Given this list of marker genes F3 (NCBI Gene Id 99486), Dusp1, Pkp1, Inmt, Car2, Fos, Myh9, Kitl, Epcam, Ccn2 (cellular communication network factor 2), Nrp1, Klf2, Klf10, Zfp36, Prkcz, Krt14, Cyp2f2, Jup, Egr1, Fzd8, Flna, Ctnnd1, Actn4, Plk2, Arhgef1, Sgk1, Id4, Sat1, Tsc22d1, Serpinb5, Itpr1, Id1, Tiam1, Chka, Id2, Stat5a, Atp1a1, Btg2, Pcx, Hmmr, Grb7, Fbp2, Numb (NUMB endocytic adaptor protein), Itgb5, Vamp8, Thbs1, Hmga2, Zfp239, Irf6, Amd1, Cdh1, Atf3, Bmp4, Padi2, Egr2, Ctsh, Nr4a1, Tgfb3, Timp3, Nnt, Tgm2, Bcl6, here is a description of the gene set: Epithelial-to-mesenchymal transition (EMT), a switch of polarized epithelial cells to a migratory, fibroblastoid phenotype, is increasingly considered as an important event during malignant tumor progression and metastasis. To identify molecular players involved in EMT and metastasis, we performed expression profiling of a set of combined in vitro/in vivo cellular models, based on clonal, fully polarized mammary epithelial cells. Seven closely related cell pairs were used, which were modified by defined oncogenes and/or external factors and showed specific aspects of epithelial plasticity relevant to cell migration, local invasion and metastasis. Since mRNA levels do not necessarily reflect protein levels in cells, we used an improved expression profiling method based on polysome-bound RNA, suitable to analyse global gene expression on Affymetrix chips. A substantial fraction of all regulated genes was found to be exclusively controlled at the translational level. Furthermore, profiling of the above multiple cell pairs allowed one to identify small numbers of genes by cluster analysis, specifically correlating gene expression with EMT, metastasis, scattering and/or oncogene function. A small set of genes specifically regulated during EMT was identified, including key regulators and signaling pathways involved in cell proliferation, epithelial polarity, survival and trans-differentiation to mesenchymal-like cells with invasive behavior. species: Mus musculus from publication Jechlinger M, Grunert S, Tamir IH, Janda E, Lüdemann S, Waerner T, Seither P, Weith A, Beug H, Kraut N (PMID 14562044) Genes down-regulated during epithelial to mesenchymal transition (EMT) induced by TGFB1 in the EpH4 cells (mammary epithelium cell line transformed by HRAS). Mouse Gene Set: JECHLINGER_EPITHELIAL_TO_MESENCHYMAL_TRANSITION_DN